Given this list of marker genes Rgs1, Klf4, Klf2, Pmaip1, Hspa1b, Hspa1a, Tsc22d3, Map4k4, Fos, here is a description of the gene set: Mouse Gene Set: CUI_CDC1_BAFF_RESPONSE_DN Cytokines mediate cell-cell communication in the immune system and represent important therapeutic targets. A myriad of studies have highlighted their central role in immune function, yet we lack a global view of the cellular responses of each immune cell type to each cytokine. To address this gap, the authors created the Immune Dictionary, a compendium of single-cell transcriptomic profiles of more than 17 immune cell types in response to each of 86 cytokines (>1,400 cytokine-cell type combinations) in mouse lymph nodes in vivo. A cytokine-centric view of the dictionary revealed that most cytokines induce highly cell-type-specific responses. For example, the inflammatory cytokine interleukin-1β induces distinct gene programmes in almost every cell type. A cell-type-centric view of the dictionary identified more than 66 cytokine-driven cellular polarization states across immune cell types, including previously uncharacterized states such as an interleukin-18-induced polyfunctional natural killer cell state. studied in species Mus musculus Genes negatively differentially expressed in cell type: cDC1 (conventional dendritic cell type 1) upon treatment with cytokine: BAFF in mouse lymph nodes in vivo. from publication Cui A, Huang T, Li S, Ma A, Pérez JL, Sander C, Keskin DB, Wu CJ, Fraenkel E, Hacohen N (PMID 38057668)